Given this list of marker genes SCN4A, ZBTB18, GRHL3, SNORD115-1, KANSL1, MSX1, COMT, PQBP1, TPM3, IQSEC2, CRLF1, DGCR2, CHAT (NCBI Gene Id 1103), SMS, SNRPB, SRPX2, UPF3B, DGCR6, ARHGEF38, TWNK, SLC5A7, UNC45B, UBB, MYPN, NOTCH3 (NCBI Gene Id 791), RIC1, ARVCF, RREB1, ARHGAP29, RILPL1, BMP4, GMPPA, TRAPPC11, SNRPN, PHF8, MYOT, PPM1B, SET, SYT2, LRP12, CEP104, GRIN2A, IL1RAPL1, SLC3A1, POLG, SPG7, NPAP1, HERC2, CDH1, PWRN1, ATG7, PREPL, DLG1, ESS2, DGCR8, COL9A1, LIFR, AMER1, AAAS, TBX1, CAMTA1, SHOC2, PLEC, COL13A1, DLX4, MKRN3, PYROXD1, DYNC1I2, CNOT2, BAG3, TUBB6, VAMP1, JMJD1C, CADM3, ERI1, HIRA, SNORD116-1, MYMX, TPM2, MGP, MUSK, AGRN, MED12, NALCN, ATP6V0A2, CAMKMT, SLC18A2, SLC25A1, PABPN1, MYO9A, PCNT, MYH3, SLC18A3, GP1BB (NCBI Gene Id 89199), MATR3, MAGEL2, MEGF10 (multiple EGF like domains 10), PDGFRA, IRF6, ZDHHC9, PWAR1, SEC24C, SELENON, NONO, NECTIN1, COBLL1, SRCAP, SNAP25, MGME1, UFD1, FOXP2, TP63, TFAP2A, here is a description of the gene set: studied in species Homo sapiens Human Gene Set: HP_HYPERNASAL_SPEECH A type of speech characterized by the presence of an abnormally increased nasal airflow during speech associated with structural abnormality of the nasal passages. Hypernasal speech